The following is a description of a gene set: studied in species Homo sapiens Human Gene Set: GOMF_HYDRO_LYASE_ACTIVITY Catalysis of the cleavage of a carbon-oxygen bond by elimination of water., and this is the list of marker genes: L3HYPDH, ENO2, ENO3, CA13, ACO1, APIP, CA9, UROC1, NAXD, ECHS1, ENO1, HADHB, ENO4, CBS, PARK7, UROS, PCBD2, CA6, CYP2S1, ENSG00000274276, IREB2, CA10, CA11, EHHADH, HSD17B4, GATD1, ECHDC3, CA1, CA5BP1, PCBD1, CA3, HACD1, CYP1A1, CDYL, CA2, FASN, TGDS, AUH, ENOSF1, CYP1A2, CA12, ACO2, HTD2, CA5B, CA5A, HADHA, DGLUCY, CA8, GMDS, CA7, CYP1B1, CA4, FH, TBXAS1, ALOXE3, ALAD, HACD4, HACD2, HACD3, PTGIS, CA14